Given this list of marker genes Zrsr2, Adat1, Pard3, Ckmt2, Hsp90b1, Amotl2, Atxn7, Mrpl4, Gnl3l, Meioc, Klf9, Stt3b, Pi4k2b, Pcnx1, Zfp57, Col11a1, Cldn34d, Alg2, Jag1, Larp4b (La ribonucleoprotein 4B), Hcn1, Klhl9, Rfx3, Caap1, St8sia3, Clip4, Tbc1d12, Pdgfra, Sf3b2 (NCBI Gene Id 78505), Prkg1, Mex3c, Dab2, Bltp1, Aggf1, Pnn, Palld, Ccdc32, Pwwp2a, Purg (NCBI Gene Id 75029), Dot1l, Cd28, Rab39, Gpcpd1, Spin1, Ltn1, Sfrp1, Lsm12, Unc13b, Asxl1, Ppargc1b, Gbe1, Azi2, Capza1, Serbp1, Kdm5a, Atf7ip2, Hoxd13, Ski, Map7d3, Naf1, Neo1, Ddx17, Esr1, Grik5, Srpra, Ythdf1, Adam10, Cul3, D1Pas1, Stim2, Scai, Zfp385b, Cdk13, Atp2c1, Lpl, Fam149b, D630045J12Rik, Edar, Mtcl2, Cd72, Ccpg1 (NCBI Gene Id 72278), Trappc6b, Thumpd2, Hipk3, Dio3, Sub1, Dync1i1 (dynein cytoplasmic 1 intermediate chain 1), Fam168a, Car13, Adamts3, Tab2, 4930523C07Rik, Pkd2, Golga4, Zfand6, Cpeb4, Lrrtm1, here is a description of the gene set: Mouse Gene Set: MIR_710 from publication Chen Y, Wang X (PMID 31504780) studied in species Mus musculus Genes predicted to be targets of miRBase v22 microRNA mmu_miR_710 in miRDB v6.0 with MirTarget v4 prediction scores > 80 (high confidence targets).